The following is a description of a gene set: species: Homo sapiens Genes up-regulated in stimulated by anti-CD3 double positive thymocytes: ELK1 knockout versus ELK1 and ELK4 knockout. Removal of the transcription factor SAP1a member of the Ternary Complex Factor (TCF) group of transcription factors which in conjunction with Serum Response Factor (SRF) has been shown to have a profound effect on positive selection in the thymus. When another TCF Elk1 is knocked out in mice there is no effect on positive selection unless it is on a Sap1a KO background where the phenotype is very severe. We have stimulated isolated double positive T cells (DPs) with anti-CD3 to mimic positive selection and compared basal and stimulated transcription across the four genotypes to discover the downstream targets of Sap1a involved in positive selection. Human Gene Set: GSE21546_ELK1_KO_VS_SAP1A_KO_AND_ELK1_KO_ANTI_CD3_STIM_DP_THYMOCYTES_UP from publication Costello P, Nicolas R, Willoughby J, Wasylyk B, Nordheim A, Treisman R (PMID 20554967), and this is the list of marker genes: ANKRD49, FGFBP3, CFAP418, SNTB1, TXLNG, ZC3H4, SCAI, NFKBIE, RNF167, INPP4A, BIVM, UVSSA, RENBP, SLC39A9, ENPP4, TIAM1, FAM216A, IFT70B, LRRC28, C1QTNF1, EXOSC4, TMEM67, FBXO38, TMEM18, HOXB4, RPP25L, TRRAP, POC1A, ARFGAP2, NDUFA8, ADAMTS1, H2AX, DARS2, TFDP1, SUV39H1, CBX5, TGM4, HCFC1, RABEPK, ZNF585A, RFX3, EIF4A3, MTIF3, LENG1, MMAA, ATG16L2, FAM118B, EVC2, NETO2, C1orf50, CFB, DFFA, THUMPD2, CYB561A3 (NCBI Gene Id 378885), PRR14, HYAL2, METTL3, TMEM205, MAPK12, NRF1, PBLD, TLR1, INCENP, CCDC71, PAPOLG, MED23, GRIA3, FKBPL, GCM2, ANTKMT, CNOT3, SETX, MARCHF6, SAP130, UBR5, IRF9, SOX18, KBTBD11, IK, ALS2, RNMT, CYRIB, POT1, NUP93, FEN1, NR2F1, MOS, TP53BP1, TUB, TTC9C, MTMR3 (myotubularin related protein 3), STAT3, HSDL1, PRR15L, DLG3, STYXL2, TRIM45, ZNF569, MYO7A, FZR1, SIPA1L1, CDCA2, KLHL42, ERBB3, MEIS2, TMEM63A, AMELX, UBA6, ZYG11B, TBC1D25, FARSA, PRKAG1, FERRY3, OR52A1, RBM5, VWA3A, TAFAZZIN, TAFA1, ZNF414, PUM2, SLC52A2, IRF4, ZSCAN21, VPS13B, SCYL3, SNX12, CHD6, SZT2, GTF3C5, C8orf48, QRICH1, ESS2, MSTO1, ZMYND8, CCDC51, GPR85, LMO2, SLC12A2, NUMA1, INHBB, SRSF6, CFAP97, ASXL2, DYNC2I1, SHPRH, SNX33, TAB1, CST8, PBXIP1, SLC35D2, MRPL50, AVL9, CCDC185, ZNF449, RERE, DRD1, PIAS1, PUF60, NKIRAS2, HEXIM1, POLD3, C3orf33, TMEM165, MLST8, ZSWIM3, ZBTB8OS, ANKS3, NUP88, NELFCD, WDR89, GLRA3, ARMC6, INTU, DDHD1, NOL12, AACS, HPS6, MUL1, RNASEH1, RBX1, GRHL2, DESI2, UBA3, ANAPC4, LURAP1L (NCBI Gene Id 286343), B3GALT6 (NCBI Gene Id 126792), RTP4, TMT1B (thiol methyltransferase 1B), ITCH, WRAP73 (WD repeat containing, antisense to TP73), SIRT4, POP5, GORASP1, KIAA0319L, USP32, CRKL, CBR4, WDR24, MUS81